The following is a description of a gene set: Genes whose expression peaked at 40 min after stimulation of MCF10A cells with serum. Human Gene Set: AMIT_SERUM_RESPONSE_40_MCF10A species: Homo sapiens Signaling pathways invoke interplays between forward signaling and feedback to drive robust cellular response. In this study, we address the dynamics of growth factor signaling through profiling of protein phosphorylation and gene expression, demonstrating the presence of a kinetically defined cluster of delayed early genes that function to attenuate the early events of growth factor signaling. Using epidermal growth factor receptor signaling as the major model system and concentrating on regulation of transcription and mRNA stability, we demonstrate that a number of genes within the delayed early gene cluster function as feedback regulators of immediate early genes. Consistent with their role in negative regulation of cell signaling, genes within this cluster are downregulated in diverse tumor types, in correlation with clinical outcome. More generally, our study proposes a mechanistic description of the cellular response to growth factors by defining architectural motifs that underlie the function of signaling networks. from publication Amit I, Citri A, Shay T, Lu Y, Katz M, Zhang F, Tarcic G, Siwak D, Lahad J, Jacob-Hirsch J, Amariglio N, Vaisman N, Segal E, Rechavi G, Alon U, Mills GB, Domany E, Yarden Y (PMID 17322878), and this is the list of marker genes: FOS, DTX2P1-UPK3BP1-PMS2P11, TOMM22 (NCBI Gene Id 56993), MCL1, EGR1, IL1A, TP63, LGMN, FOSB, DUSP1, GLRX3P2, GM2A, KLF6, CXCL3, TCTN2, SLC16A4, JUN, WEE1, GLUL, NR4A1, NAMPT, ATF3, CITED2, NR4A2, FPR1, CLIC4, ADM, CXCL2, RGS2, PVR, ZFP36, DCN